The following is a description of a gene set: Genes predicted to be targets of miRBase v22 microRNA hsa-miR-3125 in miRDB v6.0 with MirTarget v4 prediction scores > 80 (high confidence targets). Human Gene Set: MIR3125 species: Homo sapiens from publication Chen Y, Wang X (PMID 31504780), and this is the list of marker genes: ESRP1, LCE2B, BTN1A1, TMEM126B, CD302, IMPACT, CBLN4, SPTLC3, CSNK1G3, KPNA3, ATP8A1, SORBS3, ARHGEF35, UNC5C, DDO, VWA5A, NUP98 (nucleoporin 98 and 96 precursor), DDX17, FGB, HIF3A, GALR1, OSBPL6, ITCH, KATNIP, ZFYVE26, RHOQ, DLGAP4, WDR36, POLQ, ZNF550, ANK2, C1orf198, USP49, KRIT1, PRDM1, CTNNA1, LMBRD2, RNLS, LY75-CD302, GPATCH2L, HDAC9, TOR1AIP1, KIF3A, GPATCH2, ARL3, ZFP36L1, SUFU, GCFC2, LMAN1, DCX, EGLN3, ALDH5A1, HNRNPK, F9, LRRC27, DOCK5, SNX25, KCNE1, ITGB8, RABL3, GFRAL, NRCAM, TBCA, ITM2B, MACO1 (macoilin 1), MYADM, RARB, KTI12, TRIM8, CYRIB, RNF168, BTD, ATE1, KLF8, NAV3, TPRG1, STAMBP, CCNT1, TTC14, SC5D, HLA-DRA, STK39, STYK1, POGK, BUB3, SCUBE3, DLG2, NMNAT2, DEFB132, MN1, TMEM178B, FSD1L, MTMR10, TCP1, CDIN1, KRAS, AR, SPATS2, WDR19, CDH12, BTF3L4, PDE12, IRF9, TMEM19, XBP1 (NCBI Gene Id 7494), PDCL3, ATP11B, ARMCX1, RAB18, ANO6, HELQ, DIDO1, RBBP4, ELAVL4, C4orf33, VPS37A, GANAB, RALA, PDE1C, ZBTB20, AP3M2, INO80D, PI15, HNRNPR, FNDC5, ZNF365, HDGFL3, ASTN1, GDPD1, CEP135, SLC26A1, C17orf67, FAM98B, TSR2, ARID4A, TDRD1, STK35, OGA, LMBRD1, CAP1, GPLD1, SDC1, AP1AR, MLF2, SETD4, AGL, C5orf47, TP53INP2, SEC63, HERC3, BTG2, CNR1, FGF9, ABHD10, ZFP36L2, ESYT3 (extended synaptotagmin 3), XPO7, CNTN3, MAN1C1, PECAM1, KLHL31, GLDC, AGO1, DYRK1A, ZNF264, NCOA5, CAMK1D, CRADD, CREB3L2, TRA2A, EXOC6B, SUSD1 (NCBI Gene Id 64420), TRIAP1, RBM20, GATA4, SEC22B, AMER1, C11orf87, CBX3 (chromobox 3), DEPDC4, ZBTB41, GLI2, RCBTB2, OTUD7B, KRT40, SKA2, FBXO45, ALDH1A3, CTTNBP2, USB1, ZNF566, RNF212, RASAL2, DDX52, TSPAN6, ANKRD45, RC3H1, HOXB2, GXYLT1, ZNF609, RAB31, CUL4A, MED24, GNAQ, CEP350, SLC16A2, TLL2, KPNA1, BAZ1A, TEAD1, RNF212B, OTOR (otoraplin), ACVR2B, TMOD2, PANK3, CLHC1, ERCC1 (ERCC excision repair 1, endonuclease non-catalytic subunit), YLPM1, FAM120B, EPS15, SMG7, APC, ATF7IP, CFL1, CCDC190, ELFN1, MIER3, OR2L13, CLDND1, PPM1A, MMACHC, METTL13, HAUS6, VGLL3, ZDHHC3, PLEKHB1, PRDM4, KIF5B